The following is a description of a gene set: The process whose specific outcome is the progression of the primary female sexual characteristics over time, from their formation to the mature structure. The primary female sexual characteristics are the ovaries, and they develop in response to sex hormone secretion. Human Gene Set: GOBP_DEVELOPMENT_OF_PRIMARY_FEMALE_SEXUAL_CHARACTERISTICS studied in species Homo sapiens, and this is the list of marker genes: AFP, MMP2, PGR, KDR, DACH2, NPR2, TNFAIP6, INHBA, RETN, PLEKHA1, VEGFA, LHX9, FZD4, PCYT1B, ARID5B, VGF, UBB, ESR1, FANCA, ADCYAP1R1, LFNG (NCBI Gene Id 3955), CGA, ZNF830, CASP3, NPPC, WT1, DACH1, SPO11, DMC1, SIRT1, FANCG, SFRP1, NUP107, UMODL1, GAS2, SCAPER, FOXC1, NOTCH1, TAF4, SLIT2 (slit guidance ligand 2), CCDC182, KITLG, FOXO3, NR5A1, CSMD1, INSR, LHFPL2, FSHR, MMP14, RAC1, PTPRN, INHBB, WNT4, BAX, LEP, GNRH1, STAT5B, LSM14B, PTX3, ZP3, IMMP2L, FANCE, LHCGR, NUPR1, ZFPM2, HYAL3, TIPARP, ZFP42, AMHR2, NOTCH4, BRCA2, STAT5A, EIF2B4, ATM, NRIP1, CTNNA1, EIF2B5, UBE3A, FSHB, DMRTA1, NR2F2, BCL2, SLIT3, ANG, CYP19A1, ADAMTS1, IDH1, PDGFRA, CASP2, NR5A2, SGPL1, GDF9, ROBO2, KIT, INHA, MSH4, BMPR1B (bone morphogenetic protein receptor type 1B), ZFY, SMAD4, EREG, CEBPB, BCL2L1, AMH (anti-Mullerian hormone), GPR149, EIF2B2, FOXL2, NOS3, SOD1, BCAS2, FST, MMP19